The following is a description of a gene set: The orderly movement of a cell from one site to another along a substrate such as the extracellular matrix; the migrating cell forms a protrusion that attaches to the substrate. Human Gene Set: GOBP_SUBSTRATE_DEPENDENT_CELL_MIGRATION species: Homo sapiens, and this is the list of marker genes: MYH10, VEGFC, CSPG4, ITGA11, STON1, CD2AP, FN1, ROBO1, FBLN1, TNFRSF12A, ATP5F1B, ITGA2, CTTN, STK4, NTN1, EPB41L5, SHTN1, SDCBP, SLIT2, ADAM8, P2RY12, ANKS1A, PTPRC, SNAI2, EPHA8, OPHN1, NCK1, ITGB1BP1, NRP1